Given this list of marker genes AGT, MIR24-1, FXYD2, PCSK9, SNTA1, DLG1, MIR192, FGF13, NOS1, ATP1B3, OSR1, ATP1B1, SLMAP, FGF12, BPIFA1, WNK3, STK39, FXYD6, MIR448, FXYD1, ACTN4, GRP, DMD, CAMK2D (NCBI Gene Id 817), SCN1B, PTPN3, UTRN, COMMD1, NEDD4L, SCN5A, PRKCE, FXYD5, FXYD6P3, FXYD7, TESC (tescalcin), FXYD4, FXYD3, WNK1, CHP1, RANGRF, ATP2B4, CAV3, ATP1B2, WNK2, here is a description of the gene set: Any process that modulates the frequency, rate or extent of sodium ion transmembrane transport. Human Gene Set: GOBP_REGULATION_OF_SODIUM_ION_TRANSMEMBRANE_TRANSPORT species: Homo sapiens